The following is a description of a gene set: from publication Chen Y, Wang X (PMID 31504780) studied in species Homo sapiens Genes predicted to be targets of miRBase v22 microRNA hsa-miR-197-3p in miRDB v6.0 with MirTarget v4 prediction scores > 80 (high confidence targets). Human Gene Set: MIR197_3P, and this is the list of marker genes: ARMC1, TRIT1, FAM227A, PITPNB, FMN1, KPNA6, GOSR2, UGCG, ZNF189, FOXP2, RELCH, CSF1, SMAP1, TMEM19, MUC4, SVOP, MEIOB, PIANP, CD53, SLC47A2, TXLNG, CTNND1, IFNA17, C11orf71, RPL36A-HNRNPH2, TRIM25, BEND3, CBL, IL1RAP, CILP, AKAP5, CD99, ZIC3, EYA1, TXNDC12, SST, NAP1L4, KRBOX5, PLEKHA5, FBXO42, ARL6IP1, EED (embryonic ectoderm development), SLC44A1, MEF2A, RCOR1, ZNF34, ZZZ3, CDK8, CCDC85C, NYAP2, SHCBP1, MINAR1, MTX3, CD109, SERTAD4, ZNF264, TAL1, ZNF181, RFC1, JAK2, C5orf24, IGFBP3, LYSMD3, SS18, TTPAL, HEATR5B, CTNNA1, CLNS1A, ZNF614, IFNA4, SLC30A9, PPFIBP1, ADO, PSME4, FZD3, SYNGAP1, RCAN2, NRF1, P4HA1, PHACTR2, ETF1, MAPK8, HCAR1, UBR3, ANXA7 (annexin A7), MEAF6, TMEM265, EAF1 (NCBI Gene Id 85403), FGF12, TMEM87A (transmembrane protein 87A), DOCK9, INA, CECR2 (NCBI Gene Id 27443), PPM1E, STAG2, SEPTIN10, PTPN9, ATP6V1A, ADAT2, DDX52